The following is a description of a gene set: Genes predicted to be targets of miRBase v22 microRNA mmu_miR_380_5p in miRDB v6.0 with MirTarget v4 prediction scores > 80 (high confidence targets). Mouse Gene Set: MIR_380_5P species: Mus musculus from publication Chen Y, Wang X (PMID 31504780), and this is the list of marker genes: Tbc1d32, Prc1 (NCBI Gene Id 54341), Kmt2a, Crocc2 (NCBI Gene Id 633787), Apln, Shroom4, Rit1, Atp8b4, Jcad, Iqcg, Socs2, Dlat, Atg14, H2az1, S1pr1, Snai2, Hic1, Lrrc74b, Hnf4g, Dip2c, Satb2, Fst, Oxsr1, Sbds, Aff4, Necab1, Tspan18, Kcnma1, Ranbp17, Spry2, Rab39 (RAB39, member RAS oncogene family), Onecut2, Phactr2, Ms4a6b, Frk, Snx7, Ftmt, Lgr4, Cpsf6, Ms4a6c, Negr1, Mgat4c, Afg3l2, Pcdh18, Cdv3, Sult1c2, Ntng1, Gabrb2, Jpt2, Fbn1, Serac1, Adgra1, Adcy7, Tecta, Vtcn1, Elavl4, Ppp3cb, Rad23b, Xkr8, Rnf111, Cfap91, Prkar2b, Kynu